The following is a description of a gene set: Glycerophospholipids are important structural and functional components of biological membranes and constituents of serum lipoproteins and the pulmonary surfactant. In addition, glycerophospholipids act as precursors of lipid mediators such as platelet-activating factor and eicosanoids. Cellular membranes contains a distinct composition of various glycerophospholipids such as phosphatidic acid (PA), phosphatidylcholine (PC), phosphatidylethanolamine (PE), phosphatidylserine (PS), phosphatidylglycerol (PG), phosphatidylinositol (PI), cardiolipin (CL), lysophosphatidic acid (LPA) and lysobisphosphatidic acid (also known as bis(monoacylglycerol) hydrogen phosphate - BMP).<br><br>Glycerophospholipids are first formed by the <i>de novo</i> (Kennedy) pathway using fatty acids activated as acyl-CoA donors. However, the acyl groups of glycerophospholipids are highly diverse and distributed in an asymmetric manner. Saturated and monounsaturated fatty acids are usually esterified at the <i>sn-1</i> position, whereas polyunsaturated acyl groups are esterified at the <i>sn-2</i> position. Subsequent acyl chain remodeling (Lands cycle) generates the diverse glycerophospholipid composition and asymmetry characteristic of cell membranes.<br><br>In the <i>de novo</i> pathway of glycerophospholipid biosynthesis, lysophosphatidic acid (LPA) is initially formed from glycerol 3-phosphate (G3P). Next, LPA is converted to PA by a LPA acyltransferase (AGPAT, also known as LPAAT), then PA is metabolized into two types of glycerol derivatives. The first is diacylglycerol (DAG) which is converted to triacylglycerol (TAG), PC, and PE. Subsequently, PS is synthesized from PC or PE. The second is cytidine diphosphate-diacylglycerol (CDP-DAG), which is processed into PI, PG, CL, and BMP. Each glycerophospholipid is involved in acyl chain remodeling via cleavage by phospholipases followed by reacylation by an acyltransferase.<br><br>Most of the glycerophospholipids are synthesized at the endoplasmic reticulum (ER), however, some, most notably cardiolipin, and BMP are synthesized in the mitochondrial and endosomal membranes respectively. Since the most of the glycerophospholipids are found in all membrane compartments, there must be extensive network of transport of glycerophospholipids from one membrane compartment to another via various mechanisms including diffusion through the cytosol, formation of transportation complexes, and diffusion via membrane contact sites (MCS). Reactome Pathway: Glycerophospholipid biosynthesis part of: Phospholipid metabolism species: Homo sapiens, and this is the list of marker genes: STARD10, LCLAT1, PLB1, PLD4 (phospholipase D family member 4), LIPH, PTDSS1, DDHD1, ABHD4, PTPMT1, PCYT1B, PLA2G4F, SLC44A3, TMEM86B, AWAT2, OSBPL8, PCYT2, PLA2G4A, CSNK2A1, LPCAT4, LPCAT2 (lysophosphatidylcholine acyltransferase 2), PNPLA8, GPD2, PLA2G1B, ETNPPL, PLA2G10, PLA2G5 (NCBI Gene Id 5322), ABHD3, PLA2G2E, CPNE3, CHKA, GPCPD1, LIPI, CHAT, PCTP, PLA2G2D, PLAAT3, PGP, AGPAT1, PNPLA2, MIGA1, PLA2G6, GPAT3, CRLS1, OSBPL10 (oxysterol binding protein like 10), PNPLA3, CDIPT, CPNE1, PLA2R1, SLC44A1, SLC44A4, GPD1L, ETNK1, CDS1, ETNK2, GPAT2, PCYT1A, MBOAT1, GPAT4, CSNK2A2, HADHB, LPCAT1, PITPNB, CHKB, BCHE, LPIN1, PLA1A, AGPAT5, LPIN2, DGAT2L6, CEPT1, MFSD2A, PGS1, PEMT, PHOSPHO1, MBOAT2, CPNE7, PTDSS2, PLA2G4E, GPAM, AGK, LPIN3, PITPNM2, PLA2G3, DGAT1, PLAAT2, PLD1, SLC44A2 (NCBI Gene Id 57368), TAFAZZIN, MIGA2, PLA2G12A, PLA2G4C, CHPT1, PLBD1, HADHA, SLC44A5, OSBPL5, MGLL, CSNK2B, CDS2, PITPNM1, STARD7, PLD2, ACP6, AGPAT4, PLD6, PLAAT4, PLAAT5, LPCAT3, AGPAT3, GNPAT, PLD3, PLA2G2A, ACHE, PLA2G4D, DDHD2, AGPAT2, CPNE6, LPGAT1, PLAAT1, PLA2G15, ALPI, PISD, PLA2G4B, MBOAT7, PITPNM3, GPD1, PLA2G2F, SELENOI, DGAT2